Given this list of marker genes PPIA, PSIP1, APOBEC3G, HMGA1, BANF1, here is a description of the gene set: Human Gene Set: REACTOME_APOBEC3G_MEDIATED_RESISTANCE_TO_HIV_1_INFECTION studied in species Homo sapiens APOBEC3G mediated resistance to HIV-1 infection